Given this list of marker genes Gnpat, Pmp22, Cd9, Nfasc, Cntnap1, Ugt8a, Epb41l3, here is a description of the gene set: studied in species Mus musculus Mouse Gene Set: GOBP_PARANODAL_JUNCTION_ASSEMBLY Formation of the junction between an axon and the glial cell that forms the myelin sheath. Paranodal junctions form at each paranode, i.e. at the ends of the unmyelinated nodes of Ranvier.